The following is a description of a gene set: studied in species Homo sapiens Any process involved in the maintenance of an internal steady state of magnesium ions within an organism or cell. Human Gene Set: GOBP_MAGNESIUM_ION_HOMEOSTASIS, and this is the list of marker genes: CNNM2, KEL, EDN3, TRPM7, CNNM3, CNNM4, SLC41A1, CNNM1, PTH, ANK3 (ankyrin 3), XK, TMEM94, KCNA1